The following is a description of a gene set: Mouse Gene Set: GOBP_RESPONSE_TO_METHANOL studied in species Mus musculus Any process that results in a change in state or activity of a cell or an organism (in terms of movement, secretion, enzyme production, gene expression, etc.) as a result of a methanol stimulus., and this is the list of marker genes: Serpina1c, Serpina1a, Serpina1b, Serpina1d, Serpina1e